The following is a description of a gene set: from publication Tsai MH, Cook JA, Chandramouli GV, DeGraff W, Yan H, Zhao S, Coleman CN, Mitchell JB, Chuang EY (PMID 17440099) Studies were conducted to determine whether gene expression profiles following a single dose of radiation would yield equivalent profiles following fractionated radiation in different tumor cell lines. MCF7 (breast), DU145 (prostate), and SF539 (gliosarcoma) cells were exposed to a total radiation dose of 10 Gy administered as a single dose (SD) or by daily multifractions (MF) of 5 x 2 Gy. Following radiation treatment, mRNA was isolated at 1, 4, 10, and 24 h and processed for cDNA microarray analysis. To determine the influence of the tumor microenvironment on gene expression, one cell type (DU145) was evaluated growing as a solid tumor in athymic nude mice for both radiation protocols. Unsupervised hierarchical cluster map analysis showed significant differences in gene expression profiles between SD and MF treatments for cells treated in vitro, with MF yielding a more robust induction compared with SD. Several genes were uniquely up-regulated by MF treatment, including multiple IFN-related genes (STAT1, G1P2, OAS1, OAS3, G1P3, IFITM1) and TGF-beta-associated genes (EGR1, VEGF, THBS1, and TGFB2). DU145 cells grown in vivo exhibited a completely different set of genes induced by both SD and MF compared with the same cells exposed in vitro. The results of the study clearly show distinct differences in the molecular response of cells between SD and MF radiation exposures and show that the tumor microenvironment can significantly influence the pattern of gene expression after radiation exposures. species: Homo sapiens Genes up-regulated in response to both single dose and fractionated radiation that were common to all three cell lines studied. Human Gene Set: TSAI_RESPONSE_TO_RADIATION_THERAPY, and this is the list of marker genes: LGALS3BP, PLAT, TNFRSF11B, ISG15, IFIT2, TGFB2 (NCBI Gene Id 7042), LIPC, SERPINE1, CCN1, HBB, CD69, A2M, TGFBR3, CFB, IFI6, COL4A1, EGR1, TSC22D1, TGFBR2, COL6A2, CCN2, SMAD3, IFITM1, IGFBP5, IL6, VEGFC, COL6A3, COL6A1, OAS3, BST2, VEGFA, THBS1